The following is a description of a gene set: Human Gene Set: HP_ABNORMAL_NASAL_BRIDGE_MORPHOLOGY Abnormality of the nasal bridge, which is the saddle-shaped area that includes the nasal root and the lateral aspects of the nose. It lies between the glabella and the inferior boundary of the nasal bone, and extends laterally to the inner canthi. species: Homo sapiens Abnormal nasal bridge morphology, and this is the list of marker genes: IL6ST, NHS, CCND2, ZEB2, PAX3 (NCBI Gene Id 5077), PROK2, PAK3, HSPG2, ZBTB20, SVBP, RPS7, ALX3, SYNGAP1, AP4B1, SMARCD1, ALG3, TONSL, CHN1, EXT2, NCF1, IFT27, MAP2K1, KCNJ2, TCTN1, SLC6A9, AFF2, PCLO, POU1F1, FLNA, POLRMT, ARID1B, UQCC2, GLI3, DUOXA2, RAF1, BBS4, CDC42, MYRF, OFD1, POLA1, CEP41, NAGA, SETBP1, BCAS3, LMNB1, DNAJC30, NANS, PNKP, PIGN, POGZ, GTF2IRD1, RARS2, BBIP1, RAB3GAP1, EIF4A2, CDKL5, CDC42BPB, SOX18, B3GLCT, TRIP11, U2AF2, SIX3, ALX1, GLIS3, SOS1, SPECC1L, NUP188, LUZP1, KCNJ6, MADD, ALX4, PEX16, TASP1, TMEM218, FOXG1, ATP6V1A, BMPR1A, WDR11, ANKH, OTUD6B, RPL11, SKIC3, GPC6, TBX4, TRPV4, UGP2, MACF1, KIF11, PIGL, KDM6B (NCBI Gene Id 23135), HEPACAM, RPS20, TBX2, SATB2, PRMT7, TRAPPC9, RPL18, RPS6KA3, GNPNAT1, CHD2, NEXMIF, ARX, RALGAPA1, SCAPER, ADA2 (NCBI Gene Id 51816), ADAMTS3, TPM2, ERI1, NUP88, MITF, SLC4A10, FANCL, SKI, SPTBN1, SCYL2, PITX2, OBSL1, PDPN, KCNK9, MAGEL2, PIGB, SLC3A1, SNAP29, EBF3, SLC18A3, TRPM3, IFT74, GAS1, PIGY, GJA5, TMEM67, AHI1, DNMT3B, ARSL, FGD1, HERC1, CEP57, VARS1, IFT172, DYRK1A, DHX30 (DExH-box helicase 30), NOTCH3, DDX3X, CHD3 (NCBI Gene Id 1107), TUBGCP6, TMEM270, COL2A1, STT3A, RPL5, KCNAB2, GOLGA2, MAPK8IP3, ZFX, MIPEP, ALG12, WNT5A, PGAP2, ERCC6, BUB1B, METTL23, RARB, CCDC22 (NCBI Gene Id 28952), ATRX (ATRX chromatin remodeler), BLTP1, ERCC2, JAG1, TCF3, CDON, MAPK1, CRIPT, CSGALNACT1, TMEM107, SUMF1, RLIM, NDP, UBE4B, KANSL1, TBC1D24 (NCBI Gene Id 57465), FAR1, LIMK1, HNRNPK, DVL3, PURA, MAP2K2, TCTN3, PEX2, TSHB, EDAR, GDF5, NAA10, GATAD2B, DLL3, CCNQ, GBA1, CHD7, CREBBP (CREB binding protein), ADAMTSL2, PIGV, WDPCP, FBXO28, GNPAT, COX7B, PIGP, ADNP, RFC2, RPS26, SCARF2, GAD1, TUBA1A, TBX1, CASZ1, TOR1A, TAF1, RTL1, KRAS, MDM2, GLB1, AP3B1, GTF2I, KDM5C, SMARCB1, DEAF1, HIVEP2, PRPS1, ORC6, TCTN2, TUBGCP4, PCDHGC4, CTSD, SYNE1 (NCBI Gene Id 85448), GPRASP2, CUL7, VPS13B, NSD1 (nuclear receptor binding SET domain protein 1), NONO, BPNT2, PUF60, MRPS14, QARS1, PIGQ, SHANK3, SCN1B, KDM5B, SMG9, FRAS1, XRCC4 (NCBI Gene Id 7518), CDH2, AMMECR1, CCN2, NPAP1, CUL4B, TACR3, TMEM237, SLC35C1, TOPORS, EIF2AK3, VDR, SET, RPS29, FUT8, DHPS, APC2 (NCBI Gene Id 10297), HELLS, INPPL1, KDM6A, RALA, LHX4, TBL2, SEMA5A, WASHC5, PROP1, B4GALT7, MED27, TMEM231, NALCN, BBS12, POLR1B, RAC1, NSDHL, AXIN1, KCNA1, KATNB1, PEX7, RBL2, JMJD1C, HES7, GPC3, AGA, POLR3A, AHDC1, G6PC3, TCF20, POLR1C (RNA polymerase I and III subunit C), HYLS1, CHST3, SPRED2, PBX1, GPX4, PSMC1, RNF13, GRIN1, TPR, NEUROD2, FRMPD4, NR2F1, SOX4, ASXL1, POLR1D, SMARCC2, UBAP2L, SLC25A22, TRIP12, RPL31, ATPAF2, SALL4, DUOX2 (dual oxidase 2), WDR4, MAB21L1, TRMT1, TFAP2A, B3GAT3, DYNC2LI1, PAM16, AP4E1, RPS17, ECE1, INPP5E, KCNJ8, CEP295, DPYSL5, CTNND2, SMAD2, DISP1, PRKAR1B, INTS1, POR, WDR26, KIF21A, IFT140, PPP1R13L, MAF, MINPP1, PIK3R1, FGFR2, IFT122, SOST, PRKDC (protein kinase, DNA-activated, catalytic subunit), SLC6A1, MYCN, PACS2, PWAR1, IFT80, GNE, TMEM70, PEX5, EDEM3 (NCBI Gene Id 87240), PEX19, FGFRL1, CLIC2, PIGA, VPS33A, MED12L, TAOK1, NELFA, WDR35, BPTF, RPL26, UMPS, TMEM53, KCTD1, RPS24, HIRA, MLXIPL, IRX5, AP2M1, COMT, TNNT3, NXN, DRG1, AKT3, TBC1D20, ARID2, RAB34, SOX11, PRDM16, SLC12A6, AFG2A, DPH1, FILIP1, PDHA1, EBP, RIN2, TMCO1, EXOC2, PEX26, MYT1L, SIK1, ETFDH, HBA2, TAF4, LTBP1, GTF2IRD2, GNB2, GNPTAB, NSMCE3, ASH1L, DLK1, GMNN, ACSL4, ASCC3, HERC2, PEX12, FLI1, TSR2, DPYD, RREB1, LZTFL1, PSAT1, CSPP1, PRKG2, STX1A, GNAS, MGAT2, IL11RA, INTU, MTOR, NSRP1, RMRP, KIT, NRCAM, NSMF, SIX2, PEX3, ARSK, PCNT, HYOU1, PIK3CA, DVL1, BBS7, PEX13, HEATR3, MAFB, EXOSC5, TRIM8, SCLT1, PAX1, PIGG, ELN, PLXNA1, ATAD3A, SNX14, STRADA, CRKL, AGO2, PTCH1, HSD17B4, SEPTIN9, MAN2B1, TP63, RAP1B, PITX1, ALDH6A1, CBY1, FKBP6, B9D2, LEMD3, B3GALT6 (NCBI Gene Id 126792), MEGF8, CEP152, EDN3 (NCBI Gene Id 1908), SMAD4, ZBTB18, POMGNT1 (protein O-linked mannose N-acetylglucosaminyltransferase 1 (beta 1,2-)), SLC39A13, SH2B1, STRA6, COL1A1 (NCBI Gene Id 4970), EXT1, FGF3, DDB1, DUSP6, PIGU, CANT1, IQSEC2, HS2ST1, SNORD115-1, BMPER, HDAC8, KIAA0586, SH3PXD2B, BUD23, RPL35, FZD2, SLC1A4, PTEN, AGL, TEFM, SP7, GALNT2, PEX11B, ARL3, RPL9, CDK13 (cyclin dependent kinase 13), USB1 (NCBI Gene Id 79650, U6 snRNA biogenesis phosphodiesterase 1), MYOD1, DNA2, RPL10, FGF8, PIGW, ZDHHC9, KAT8, FREM1 (FRAS1 related extracellular matrix 1), TFE3, SLC5A5, UHRF1, FBN1, KAT5, NFASC, PDGFRB, MYH3, PIGO, DMXL2, KDM4B, ESCO2, LBR, PAH, AFG2B, PEPD, CENPF, SIM1, LMNA, TMEM147, RBM10, KCNJ5, CD96, RPS27, SMS, MIA3, TRPV6, SHROOM4, NEK1, ADGRG6, COLEC11, RNU4-2, PUS7, PTCH2, PLOD1, ABCC9, PIEZO2, ACTG2, KPTN, TTC8, RYR1, SON, CDK10, PARS2, SCUBE3, MED13, TCF4, NPHP1, ZNF335, GNRH1, RAPSN (NCBI Gene Id 85713), SUFU, RHOA, SMPD4, LRPPRC, SEC24C (NCBI Gene Id 9632), SMARCA2, MKRN3, ARL13B, H4C5, VPS35L, P4HTM, TAF6, UNC80 (NCBI Gene Id 84540), SOX10, MED12, KISS1R, PIK3R2, PDE4D, RPL27, HNRNPR, WAC, YARS1, CHD5 (NCBI Gene Id 26139), GRIP1, RAI1, CDCA7, NFIB, ALG2, CTBP1, PIBF1, ASXL3, DLL1, PORCN, GJA1, CDKN1C, SLC2A1, PIK3CD, SNORD116-1, COL11A2, LFNG, GATA4 (GATA binding protein 4), FLII, AUTS2, FLNB, KREMEN1, RPL8, TMEM216, CRLF1, TNPO2, DHCR24 (NCBI Gene Id 9800), VPS37D, COL18A1, DHX9, SMARCAL1, AGO1, SHH, IFT52, LRP2, COG5, SEMA3E, TMEM138, CACNA1C, IGF1R, RAB23, BMP4, PLCB3, BBS2, ETFA (NCBI Gene Id 2108), MUSK, RPGRIP1L, SIN3A, PRKAR1A, NOG (noggin), ATP6V0A2, DOK7, PPM1B, IYD, JARID2, HUWE1, FOXL2, GNS, NEU1, MMP23B, STX16, MGP, NPR2, SMC1A, PDE6D, HECW2, RYR3, ASPH, ETFB, WLS, RSPRY1, TGIF1, FBXO31, PIK3C2A, TRIO, KNSTRN, PMM2, GRM7, CILK1, ACTB, SNAI2, CHD8, THSD1, UBE3B, MKKS, SOX6, KIFBP, SCNM1, GABRD, AKT1, PRIM1, WDR37, CPLX1, CEP120, SHOX, IFT56, CSNK2A1 (NCBI Gene Id 1457), COG1, RPS28, BRPF1, SMARCA4, RPS23 (NCBI Gene Id 6228), FGF17, RIPK4, INSR, PRKD1, BRCA1, MRAS, PGAP3, EFEMP2, LZTR1, AP4S1 (NCBI Gene Id 11154), PGAP1, EEF1A2, ANK1, EPG5, FOXH1, RB1, ANTXR1, COL9A3, ATIC, MYMK, ARVCF, NRAS, DPH2 (NCBI Gene Id 1802), SF3B4, MAP3K7, FDFT1, EZH2, CCNK, RECQL, CRIPTO, MTX2, WARS2, TENT5A, KCNH1, GHR, XYLT1, CASK, MARS2, SPOP, LINS1, DYNC2I1, FGFR1, KATNIP, TRPS1, NUDT2, LIG4, POLR1A (RNA polymerase I subunit A), SRD5A3, TLK2, STAG1, SLC32A1, ADAT3, GJA8, PUM1, SEC23A, DOCK7, SNRPN, DPF2, FTSJ1, KYNU, RPL35A, OPHN1, UPF3B, TMEM94, TPO, NODAL, GTPBP2, CCBE1, HECTD4, FUCA1, SPRY4, SPRTN, DDR2, TRRAP, KMT5B, PAICS (phosphoribosylaminoimidazole carboxylase and phosphoribosylaminoimidazolesuccinocarboxamide synthase), KMT2D, TWIST1, MED13L, PGM2L1, SCO2, CTU2, MTHFR, NF1, RPS15A, ADAMTS2, CKAP2L, USP9X, TBX6, SMC3, MKS1, PRKCZ, NDUFB11, HBA1, EED, SRCAP, IARS2, HS6ST1, PAK2, PTH1R, WNT7A (Wnt family member 7A), PKDCC, ALG9, CEP290, WBP4, RNF2, ARSB, KIF7, IDUA, ZNF292, DICER1, LETM1, PHF21A, COL1A2, SOX9, CLIP2, FGFR3, DYNC2H1, KIF14, CRELD1, SLC45A1 (NCBI Gene Id 50651), DCHS1, COL27A1, FBXL4, PLK4, KAT6A, FREM2, RSRC1, SETD2, HDAC4, FOXC1, GNAO1, SCN2A, MAN1B1, AMER1, RIPPLY2, HCCS, EYA1, KIAA0753, BBS5, ROR2, HBB, POLG2, STAT3, C1GALT1C1, STAG2, BBS9, KCNMA1, EDNRA, CPLANE1, RFX7, BRF1, UBE2A, IPO8, BICRA, BBS1 (Bardet-Biedl syndrome 1), MEF2C, ACTG1, METTL27, SMOC1, ERCC1, ARMC9, ARL6, ERF, PPP1R21, PWRN1, ZSWIM6, EDARADD, CDH11, GP1BB, MMP2 (matrix metallopeptidase 2), SCN1A (sodium voltage-gated channel alpha subunit 1), EXTL3, SKIC2, TOE1, BCKDK, EDNRB, NECTIN1, SETD5, FAT4, NEPRO, TBCE, MN1, FAM20C, COL3A1, MEG3, FBXO11, SCN4A, RAC3, RELN, TALDO1, FBXL3, PEX1, ANKRD11, GABBR1, DPM1 (NCBI Gene Id 8813), NHLH2, IGBP1, ARID1A, PTPN11, COG8, BCOR, PEX14, MAPRE2, RAD21, TXNL4A, PEX6, HRAS, PQBP1, EXOSC1 (NCBI Gene Id 51013), RPS10, PSMD12, CBL, KMT2A, RECQL4, KAT6B, TRIM32, TOGARAM1, RPS19, IFT57, ADAMTS10, RAB3GAP2, NMNAT1, ZMIZ1 (NCBI Gene Id 57178), NSUN2, TAPT1, AIFM1, BRD4, RPL15, ERCC5, KCNE5, NOTCH2, DCAF17, TBCK, ZBTB24, SLC25A24, SLC26A2, TFAP2B, UFD1, SMO, SLC35A2, ZMPSTE24, CTCF, BAZ1B, SMARCE1, DIS3L2, MDH1, CNOT1 (NCBI Gene Id 51579, CCR4-NOT transcription complex subunit 1), ATP6V1B2, GNRHR, HOXB1, DHCR7, FAM149B1, KDM1A, CAMSAP1, GLUL, KISS1, B9D1, H4C11, CLP1, BCR, PEX10, BMPR1B, NDE1, ZNF526, GATA1, FH, SPEN, WDR19, COG4, ACBD6, H4C9, RTTN, MESP2 (mesoderm posterior bHLH transcription factor 2), ZNF699, DPH5, SUPT16H, SOX5, CAMKMT, RHOBTB2, ADAMTSL1, ACOX1, HYAL1, TGFB3, ZIC2, HMGA2, DOCK6, LHX3, NBN, COL11A1, BBS10, SDCCAG8 (NCBI Gene Id 10806), RNU4ATAC, MECP2, TG, COX4I1, NFIX, ZNF423, TUBB, IFT81, TNNI2, MPV17, B4GALT1, EFNB1, LAMA5, RUNX2, TAC3, EP300, DYNC2I2, RERE, PREPL, LTBP3 (latent transforming growth factor beta binding protein 3), WARS1, FOCAD, TRIM37, GPC4, DBR1, TOMM7, LARP7, CEP104, KLHL7, CEP19, HESX1, ACAN, LTBP4, LONP1, ACY1, EIF4H, KCNN3, TWIST2, ZMYM2, TCOF1, PIGT, IDS, ESAM (NCBI Gene Id 90952), MEIS2, NIPBL, EDA, MID1, BMP2, PROKR2 (prokineticin receptor 2), GLI2, RAB18, CFAP418, BRAF, POLE, NSD2, H3-3A, CC2D2A, VANGL2